The following is a description of a gene set: Human Gene Set: HP_AREFLEXIA_OF_UPPER_LIMBS species: Homo sapiens Areflexia of upper limbs Inability to elicit tendon reflexes in the upper limbs., and this is the list of marker genes: SBF2, IGHMBP2, SLC9A1, CLPB, DKK1, SPTAN1, XK, JAG1